Given this list of marker genes PRDX5, GSTZ1, MGST3, HBA1, SOD2, DUOX2, MB (myoglobin), GSR, GPX6, GPX4, PRDX3, HBM, KDM3B, TXNRD3, GPX2, GPX1, HBG1, TXNRD2, NXN, MGST1, PRXL2A, HBD, SELENOT, LTC4S, SOD3, EPX, HBA2, GPX5, SRXN1, APOM, GSTA1, FABP1, S100A9, PXDNL, DUOX1, TXNDC2, TP53INP1, MGST2, SELENOW, TXNDC17, LPO, ALOX5AP, GSTO2, IPCEF1, PTGS1, HDAC6, MPO, CLIC2, PTGS2, APOA4, TXN, TXNRD1, HBE1 (hemoglobin subunit epsilon 1), GPX3, PRDX2, LRRK2, MT3, SESN2, PARK7, GSTT1 (glutathione S-transferase theta 1), CAT, SOD1, SELENOF, TPO, HBQ1, UBIAD1, CP, ALB, SELENOS, HBB, PXDN (NCBI Gene Id 7837), GSTO1, GPX8, PRDX6, HBG2, HP, PRDX1, CYGB, PRDX4, GSTM2, GSTK1, GPX7, HBZ, PTGES, APOE, GSTP1, AMBP, here is a description of the gene set: species: Homo sapiens Human Gene Set: GOMF_ANTIOXIDANT_ACTIVITY Inhibition of the reactions brought about by dioxygen (O2) or peroxides. Usually the antioxidant is effective because it can itself be more easily oxidized than the substance protected. The term is often applied to components that can trap free radicals, thereby breaking the chain reaction that normally leads to extensive biological damage.